The following is a description of a gene set: Human Gene Set: GSE17721_CTRL_VS_LPS_4H_BMDC_UP from publication Amit I, Garber M, Chevrier N, Leite AP, Donner Y, Eisenhaure T, Guttman M, Grenier JK, Li W, Zuk O, Schubert LA, Birditt B, Shay T, Goren A, Zhang X, Smith Z, Deering R, McDonald RC, Cabili M, Bernstein BE, Rinn JL, Meissner A, Root DE, Hacohen N, Regev A (PMID 19729616) mouse primary BMDCs were stimulated with tlr ligands and gene expression changes were profiled on Affymetrix arrays species: Homo sapiens Genes up-regulated in comparison of control dendritic cells (DC) at 4 h versus those stimulated with LPS (TLR4 agonist) at 4 h., and this is the list of marker genes: C19orf53, TMEM175, CCR2, RNASE4, ATP5F1A, SEC24D, UFSP2, LDLRAP1, IL6ST, FBXO8, C1QBP, PPP1R18, ELOVL5, AP1AR, TMEM14C, ATP5MG, MPDU1, IDH3A, CDIP1, PNO1, MAPK3, PGRMC2, CENPF, IRAK1BP1 (NCBI Gene Id 80793), NUDCD3, MIDN, RPS3, LMNB2, HMBS, CRK, RNH1, H2AX, CYBC1, RNF38, ABCD2, DMAC1, TIAM1, PARD6A, ADNP, SCP2, PTP4A2, DIP2B, SLC16A3, RAB31, PRKCD, NEU1 (NCBI Gene Id 4758), SUPT16H (SPT16 homolog, facilitates chromatin remodeling subunit), RASSF5, ACOT13, LSM1, CPT2, EVI5, AP5M1, PAG1, MYO9B, RAC1, OPN3, MRPL2, ANP32B, MCM7, CAPN15, ZMIZ2, RALBP1, ANKH, AATF, ARMC7, NDUFS5, PIK3CG, RGS19, ZC3H14, MED30, BDH1 (NCBI Gene Id 622), DIDO1, ITGB2, KLF16, HNRNPUL2, DPH2, HIP1, MOCS2, NDUFA7, SLC30A5, C6orf136, KLHL22, ALKBH4, SETDB1, TBL2 (transducin beta like 2), SMARCAD1, NDUFA10, TMEM203, UGGT1, IL6R, DNM1L, NR1D2, CANX, SSBP2, EEPD1, TMED9, ADRB2, NDUFA4, DIS3, RPS6KB2, ELOF1, GCDH, TMEM30A, HEPACAM2, MRPL11, WBP11, BSN, TESK2, FAM50A, P2RX4, ATG10, SKP1, LCLAT1, DLG1, MRPL36, SRRD, TLN1, HTATIP2, XBP1, ARCN1, STARD3NL, AIRN, MTAP, CPPED1, HM13, MTFMT, WASHC2A, MGAT2, NR5A1, NGRN, MPHOSPH9, GPR146, RARS2, FAM193B, FASTKD1, SLC26A6, SPG21, ELOVL6, KCMF1, PLEKHG2, SLC25A39, LIMK1, AKR7A2 (aldo-keto reductase family 7 member A2), RFC1, CTR9, PARP16, NCOR2, INPP5E, SGSM3, NLK, CLEC6A, OSBPL2, EMC6, RBBP4, SYT1, SELENBP1, PTPRO, ORC5, RPA2, DTNBP1, SRSF9, CRCP, SYNPO, NSF, MGAT5, FBXO9, PABPN1, MDH2, IFI30, PCYOX1, ALDOA, ELP2, VAC14, DNAJC9, CPT1A, KL, RTN4, NAXE, NINJ1, TOPBP1, TGFBI, PHAX, STRBP, GEMIN6, RPL6, BRCC3, PALD1, BRAT1, IPPK, TIMM10B, HEXIM1, CRADD, SEC16A, REV3L, HCFC1, HELZ, RPS26, CENPV, IDUA